The following is a description of a gene set: Human Gene Set: GOBP_ATP_METABOLIC_PROCESS The chemical reactions and pathways involving ATP, adenosine triphosphate, a universally important coenzyme and enzyme regulator. species: Homo sapiens, and this is the list of marker genes: PRKACA, NCOR1, GPD1, NDUFAB1, CLPX, NDUFB6, STOML2, NUDT2, TREX1, MLST8, NDUFA2, HSPA1A, BAD, ATP5MC1, MT-ATP6, BLOC1S6, FOXK1, IER3, SLC25A13, SLC25A25, NDUFS3, MT-ND1, TSPO, UQCC3, TAFAZZIN, VPS9D1, ALDOA, ATP6V0C, DHTKD1, HSPA1B, RPTOR, SDHB, NDUFA3, TRIM63, ATP5MJ, NDUFB4, UCP2, APP, IFNG, AK2, SELENON, ATP5MG, ATPSCKMT, STAT3, SPHK2, GCK, NDUFB10, NUDT5, ARNT, PSEN1, ENO3, BEND3, AK4, PGK2, NDUFV3, ATP6V1B2, ATP5IF1, PFKFB1, MT-ATP8, PFKFB2, CTNS, PGK1, NDUFA8, ATP5ME, ACTN3, ATP6V1A, ALDOC, FBP1, ATP1B1, ATP1A2, NDUFB1, ATP5F1A, HK3, SDHD, FLCN (NCBI Gene Id 201163), PFKM, GAPDH (NCBI Gene Id 2597), ATP5F1EP2, HKDC1, NDUFA7, PRKAA2, FKRP, COL6A1, OGDHL, NDUFV1, CBFA2T3, NT5E, ATP5MC3, NDUFV2, HTR2A, ABCC6, FAM3A, MYH4, PFKP, OLA1, ATP5F1D, IL4, EIF6, ZBTB20 (zinc finger and BTB domain containing 20), INSR, LDHC, ABCC9, ATP5MK, NDUFA1, GIT1, LIPA, GALK1, COX11, MT-ND5, PGAM1, HSPA8, ADCY10, MTCH2, PARP1, ADPGK, LDHA, PARG, MT-ND6, TMSB4X, EP300, SLC4A4, NDUFS1, MT-ND3, TPI1, ATP5F1E (ATP synthase F1 subunit epsilon), PRKAG2, NDUFB2, MFSD8, NDUFB7, MT-ND2, FIGNL1, MYH3, PGAM2 (phosphoglycerate mutase 2), NDUFB5, TGFB1, NDUFC2, NDUFA12, NDUFS5, MTOR, AK5, ATP5PD, ATP5F1C, NDUFS2, NDUFA10, ATP6V1B1, ATP5MGL (ATP synthase membrane subunit g like), MLXIPL, NDUFS4, MYH8, PKM, SRC, PKLR, KAT2B, P2RX7, AK1, TREM2, MIR675, ATP7A, ATP5PF, NDUFS7, PFKL, NDUFB8, NDUFB11, HK2, NDUFB9, MYH7, OGDH, ENPP1, BCL2L13, PGAM4, GAPDHS, ALDOB, NUPR1, MYH6, PRKAA1, AMPD2, NDUFA6, NDUFA13, PGM1, ATP5PO, PRKN, JMJD8, PRXL2C, PFKFB3 (6-phosphofructo-2-kinase/fructose-2,6-biphosphatase 3), TIGAR, ATP5F1B, PINK1, NDUFA9, SIRT6, NDUFC1, ARL2, ANTKMT (adenine nucleotide translocase lysine methyltransferase), FOXK2, MAP2K1, ATP5MF, NDUFB3 (NCBI Gene Id 4709), NDUFA5, LETMD1, SDHA, HIF1A, ENO2, DDIT4, ENO1, BPGM, DMAC2L, SLC2A6, PRKAG1, ATP5MC2, MT-ND4, HDAC4, NMNAT1, ENO4, ENPP3, DNAJC30, HK1, PRKAG3, NDUFS6, NADK, ZBTB7A, VCP, DNM1L, SLC4A1, NDUFA11, UCHL1, OGT, MT-ND4L, PPARA, FIS1, PID1, GPI, SDHC, INS, ATP5PB, PPP2CA, NDUFS8, IGF1